The following is a description of a gene set: The proteolytic removal of a signal peptide from a protein during or after transport to a specific location in the cell. Human Gene Set: GOBP_SIGNAL_PEPTIDE_PROCESSING species: Homo sapiens, and this is the list of marker genes: SPCS2, SEC11B, PARL, PCSK5, FURIN, SEC11C, HM13, SEC11A (NCBI Gene Id 23478), SPPL3, IMMP2L, SPCS3, IMMP1L, CLN5, SPCS1